The following is a description of a gene set: from publication Litvak V, Ramsey SA, Rust AG, Zak DE, Kennedy KA, Lampano AE, Nykter M, Shmulevich I, Aderem A (PMID 19270711) studied in species Homo sapiens The innate immune system is a two-edged sword; it is absolutely required for host defense against infection, but if left uncontrolled can trigger a plethora of inflammatory diseases. Here we used systems biology approaches to predict and validate a gene regulatory network involving a dynamic interplay between the transcription factors NF-κB, C/EBPδ, and ATF3 that controls inflammatory responses. We mathematically modeled transcriptional regulation of Il6 and Cebpd genes and experimentally validated the prediction that the combination of an initiator (NF-κB), an amplifier (C/EBPδ) and an attenuator (ATF3) forms a regulatory circuit that discriminates between transient and persistent Toll-like receptor 4-induced signals. Our results suggest a mechanism that enables the innate immune system to detect the duration of infection and to respond appropriately. Genes down-regulated in comparison of unstimulated macrophage cells versus macrophage cells stimulated with LPS (TLR4 agonist) for 240 min. Human Gene Set: GSE14769_UNSTIM_VS_240MIN_LPS_BMDM_DN, and this is the list of marker genes: SRC (SRC proto-oncogene, non-receptor tyrosine kinase), IRF9, SESTD1, CAMLG, NCOA7, CPEB4, MOV10 (Mov10 RNA helicase), MITF, GTF2B, MIER3, XKR8, WHAMM (WASP homolog associated with actin, golgi membranes and microtubules), VOPP1, TRIM26, SLC49A4, TFEC, KRIT1, RNF114 (NCBI Gene Id 55905), TXLNG, RAB3IP, ATAD2B, LRP11, NFIX, AKT3, YJU2, TANK, ZNRF1, TOR3A, ACSL1 (acyl-CoA synthetase long chain family member 1), SMG8, TRAF5, IZUMO2, CDKN1A, PHOSPHO2, CHD9, UBE2Z, GTPBP6, KAT6A, RNF135 (NCBI Gene Id 84282), BMERB1 (NCBI Gene Id 89927), DOCK10, TMOD3, HTT, NAT1, MED12 (mediator complex subunit 12, NCBI Gene Id 9968), TCF4, TOX4, SLU7, ACOT9, EVA1B, PPP1R10, ZNG1B, AGFG1, PPARGC1B, ARHGAP26, PLOD3, RELA, TEX12, ASAH2, C8orf33 (NCBI Gene Id 65265), NIBAN1, MAPKBP1, NUB1, FZD7, PHF21A, OAS3, CSF2RB, CLIC4, SRGN, BRWD3, RAB29, IL1RN, ZC3H10, DAAM1, RANBP2, RAB22A, ZNF800, USP42, WARS1, SLFN5, STAT3, TGM2, FBXO7, ADAR, FILIP1L, ABHD17B (abhydrolase domain containing 17B, depalmitoylase), CD83 (NCBI Gene Id 9308), GBP7, RGL1, CD274, CHAC2, DDT, ABCG8, PLCL2, ARHGAP31, FEZ2, FAM53C (NCBI Gene Id 51307), FLT1, SLC25A22, JUNB, DYNC1I2, CHST7, FLNB, PSME1, ZNF407, GALR1, STX6, EXOC6, ARHGAP35, MGAT4A, VCPIP1, SPRYD7, RBBP8, TRIOBP, ESRRA, GPR85, NKX2-8, CPSF7, LRRC41 (leucine rich repeat containing 41), ADAP2 (ArfGAP with dual PH domains 2), SEH1L, SEMA4D, MIER1, MAP3K8, GNL1, KYAT3, DTWD1, DCP2, TAPBPL, BCL2A1, KCTD12, HIVEP1, SLC25A12, SLC25A28 (NCBI Gene Id 81894), ZDHHC18, CLP1, PODN, SPRED1, FCF1, MVP (NCBI Gene Id 9961), APAF1, TASOR2, ATP6V0A2, NOCT, RNF34, LY96, MMP13, MTMR11, TIAM1, RRAS2, IL10, PLEKHA2, LRCH1, TENT5A, CPSF2, DEDD, ARID4A, DYRK2, SLC30A7, TNFSF9, TMEM50B, PGS1, TRAF2, TNFAIP2, TXNDC9, ATF3, RMDN3, ADGRG6, BLCAP, SLAIN1, MACIR (NCBI Gene Id 90355), NCK1, CACNB3, P2RY14, TLE3, CNTD1, TMBIM6, FLRT3, CCNL1, IL10RA, RASA4, CXCL3, RSBN1, GMEB2, PIAS1, PLAGL2 (NCBI Gene Id 5326), UBE2E2, HIVEP2, USP49, CGGBP1, LZTFL1, ABR, PTK7, BIRC2, FNDC3B, SKIL, MTDH, FZD1, OTUD5, ALDH1B1